Given this list of marker genes PLOD2, CXCL6, FBN1, TWSG1, CALU, CXCL1, PXDN (peroxidasin), THBS2 (NCBI Gene Id 7058), CSF3, MMP1, CEMIP, IL1B, B4GALT1, GREM1, LOXL2, LRRC17, CXCL3 (NCBI Gene Id 2921), CDH2, CCL7, GFPT2, TNFAIP6, IL6, PLOD1, PTGS1, LOXL1, CCL2, PTX3, RAI14, SERPINH1, CXCL5, KDELR3, SERPINE1, here is a description of the gene set: Neighborhood of MMP1 matrix metallopeptidase 1 (interstitial collagenase) in the GNF2 expression compendium Human Gene Set: GNF2_MMP1 Neighborhood of MMP1 species: Homo sapiens